The following is a description of a gene set: studied in species Mus musculus Any process that activates or increases the frequency, rate or extent of cell-cell adhesion mediated by cadherin. Mouse Gene Set: GOBP_POSITIVE_REGULATION_OF_CELL_CELL_ADHESION_MEDIATED_BY_CADHERIN, and this is the list of marker genes: Tjp1, Afdn, Wnt5a, Smad7, Dennd6a, Adam19, Wnt3a, Ptpru, Flot1